The following is a description of a gene set: Any process that activates or increases the frequency, rate or extent of establishment or extent of a membrane potential, the electric potential existing across any membrane arising from charges in the membrane itself and from the charges present in the media on either side of the membrane. studied in species Mus musculus Mouse Gene Set: GOBP_POSITIVE_REGULATION_OF_MEMBRANE_POTENTIAL, and this is the list of marker genes: Gria1, Ndufc2, Pias3, Tmem135, Bid, Mfn2, Ctns, Nnt, Mfn1, Gsk3b, Slc34a1, Ank3, Akt1, Gimap3, Gimap5, Myc, Vcp, Drd1, Prkn, Ucn3, Glrx, Mtln (mitoregulin), Hnf1a, Bad